The following is a description of a gene set: Enables the transfer of adenine, 6-aminopurine, from one side of a membrane to the other. Human Gene Set: GOMF_ADENINE_TRANSMEMBRANE_TRANSPORTER_ACTIVITY studied in species Homo sapiens, and this is the list of marker genes: SLC43A3, SLC29A2, SLC25A4, SLC29A1, SLC25A5